Given this list of marker genes COG6 (component of oligomeric golgi complex 6), COG2, RABEPK, GOLGA1, SYS1, COG5, COG4, COG1, NAPB, RAB9B (NCBI Gene Id 51209), GCC1, NAPG, COG7, SCOC, NAA35, ARFIP2, STX16, RGP1, COG8, NAPA, RAB43, VPS51, ARFRP1, NAA38, GCC2, RAB6A, TMF1, VPS52, USP6NL, NAA30, PLIN3, COG3, VAMP4, ARL1, RAB9A, VAMP3, NSF, RAB6B, IGF2R (insulin like growth factor 2 receptor), TGOLN2, VTI1A, STX10, VPS54, VPS53, M6PR (mannose-6-phosphate receptor, cation dependent), STX6, RIC1, RHOBTB3, GOLGA4, here is a description of the gene set: Retrograde transport at the Trans-Golgi-Network species: Homo sapiens Human Gene Set: REACTOME_RETROGRADE_TRANSPORT_AT_THE_TRANS_GOLGI_NETWORK